The following is a description of a gene set: Enables the transfer of carbon dioxide (CO2) from one side of a membrane to the other. species: Homo sapiens Human Gene Set: GOMF_CARBON_DIOXIDE_TRANSMEMBRANE_TRANSPORTER_ACTIVITY, and this is the list of marker genes: RHCG, RHBG, AQP6, RHAG, AQP1